Given this list of marker genes Rnf139 (NCBI Gene Id 75841), Gm30563, Has2, Deptor, Enpp2, Gsdmc3, Gm7595, Nsmce2, Ccn3, 4930402D18Rik, Fer1l6, Gm22299, Gm9920, Gm20150, Gm10370, Has2os, Gm19510, Zhx2, Gsdmc4, Zfp572, Macroh2a3, Gm7708, Gm27242, Washc5, 4930544F09Rik, 1700065I16Rik, Colec10, Taf2, Gm26684, Gm26178, Slc22a22, Gm49212, Fam83a, Gsdmc2, Atad2, Tatdn1, Col14a1, Mtss1, Myc, Gsdmcl1, Anxa13, D030024E09Rik, Hba-ps3, Gm7691, Gm24696, Gm24041, Gsdmc (gasdermin C), Gm30159, Derl1, A1bg, Gm19077, Gm41333, Gm7814, Gm18154, Kcnq3, Gm18094, Gm30929, Gm20717, Zhx1, Adcy8, Ndufb9, Gm29904, Gm5473, Gm6392, Gm10926, Lratd2, Gm23907, Pvt1, Dscc1, Tsg101-ps, Ntaq1, Gm23835, Gm2991, Gm46516, Gm46507, Gm2582, Fbxo32, Gm5673, Gsdmcl2, Gm7713, Trmt12, Mrpl13, Gm25875, Klhl38, 4930478E11Rik, Fam91a1, Gm22521, Mtbp, Tmem65, Cyrib, 4933412E24Rik, Gm5046, Gm17892, Sntb1, 4930449C09Rik, Gm7577, Gm30691, Ube2d4, Gm46499, 9130401M01Rik, Gm49229, Hhla1, Sqle, Gm5215, Gm2682, Gm4774, Gm20070, Gm41325 (predicted gene, 41325), Gm7083, Gm7566, Gm23475, Gm18787, Gm2675, Asap1, Efr3a, 1700040F17Rik, Tnfrsf11b, Gm36617, Gm7086, Rpl7-ps8, 9330154K18Rik, Gm4942, Gsdmcl-ps, Gm18152, Gm22488, 1700010G06Rik, 9930014A18Rik, Gm25628 (predicted gene, 25628, NCBI Gene Id 115488588), Gm41335, Tbc1d31, Gm38563, Trib1, Mal2, Samd12, Oc90, Gm16006, Gm7489, here is a description of the gene set: Mouse Gene Set: chr15D1 species: Mus musculus